Given this list of marker genes SYNE1, TP53, USP48, ATRX, KLHL41, BRAF, CFL2 (cofilin 2), TPM2, FLNC, ORAI1, LMOD3, ACTA1, NEB, CASQ1, CDH23, KCNK9, NR3C1, STIM1, MYPN, USP8, TFG, TPM3, here is a description of the gene set: Human Gene Set: HP_FATIGUABLE_WEAKNESS_OF_PROXIMAL_LIMB_MUSCLES A type of weakness of a skeletal muscle of proximal part of a limb that occurs after a muscle group is used and lessens if the muscle group has some rest. That is, there is diminution of strength with repetitive muscle actions. Fatiguable weakness of proximal limb muscles studied in species Homo sapiens